Given this list of marker genes LDB3, HADHA, MYOT, KLHL9, GIPC1, HADHB, TRPV4, RILPL1, MYH14, CAV3, NOTCH2NLC, PNPLA2, LRP12, NEB, CLCN1, CRYAB, here is a description of the gene set: Progressive distal muscle weakness species: Homo sapiens Progressively reduced strength of the distal musculature. Human Gene Set: HP_PROGRESSIVE_DISTAL_MUSCLE_WEAKNESS